Given this list of marker genes Pask, Sowahb (NCBI Gene Id 78088), Ube4b, Uhrf1, Entpd2, Timeless, Rnf222, Stx4a, here is a description of the gene set: from publication Chen Y, Wang X (PMID 31504780) species: Mus musculus Mouse Gene Set: MIR_688 Genes predicted to be targets of miRBase v22 microRNA mmu_miR_688 in miRDB v6.0 with MirTarget v4 prediction scores > 80 (high confidence targets).